The following is a description of a gene set: studied in species Mus musculus Mouse Gene Set: chr6F2, and this is the list of marker genes: C1ra, Cdca3, Necap1, Chd4, Gm23751, Vmn2r19, Lag3, Clec4b2, Lpcat3, Vamp1, Vmn2r26, Gm24843, Gm5317, Iffo1, Vmn2r21, Scarna10, Vmn2r22, Ptms, Tpi1, Gm22724, Gm5883, Spsb2, Eno2, Vmn2r20, Gm44823, Vmn2r-ps33, Clec4a4, Rnu7, Cd27, Clstn3, Ing4, Mir200c, Atn1, Vmn2r-ps32, Gm22763, Vmn2r23, Mrpl51, Mir141, Tapbpl, Acrbp, Lpar5, Usp5, Gm32536, Grcc10 (gene rich cluster, C10 gene), Gm44096, Gm24175, Ptpn6, Pianp, 1700027F06Rik, Emg1, Gnb3, Mir7231, Gm18840, C3ar1, 2010008C14Rik, Clec4d, Pex5 (peroxisomal biogenesis factor 5), Clec4e, Mir7045, Gm6308, Gm23547, Gapdh, 1700013D24Rik, Clec4b1, Mir8113, Vmn2r-ps31, Gm23554, Cd163, Nop2, C1rl, 4930417O13Rik, Gm6423, Gm22946, Gm23079, Vmn2r27, Lrrc23, Vmn2r25, Gm22916, Gpr162, Cops7a, C1s2, C1rb, Phb2, Mlf2, Clec4a3, C1s1 (complement component 1, s subcomponent 1), Clec4n, Clec4a1, Vmn2r24, Clec4a2, Vmn2r-ps34, Mir3098, Gm5316, Zfp384, A230083G16Rik, 4930557K07Rik, Ncapd2 (NCBI Gene Id 72814), P3h3, Cd4